The following is a description of a gene set: Genes having at least one occurrence of the motif AGATADMAGGGA in the regions spanning 4 kb centered on their transcription starting sites. This matches the GATA4 transcription factor binding site V$GATA4_Q3 (v7.4 TRANSFAC). studied in species Homo sapiens Human Gene Set: GATA4_Q3, and this is the list of marker genes: SMAD6, LHX6, POU6F2, TSHZ2, EBF1, SOX2, ARF6, WFIKKN2 (WAP, follistatin/kazal, immunoglobulin, kunitz and netrin domain containing 2), GTF2A1, LYVE1, FNBP1L (NCBI Gene Id 54874), LHX4, CNTF, HTR2B (NCBI Gene Id 3357), CLDND2, NEXN, PPP1R3D, ACTN1, SP6, HOXB2, RASAL2, ESRRG, LMO3, TEX9, SMC1B, FAM53B, CREB3, MYB, MAP3K20, DLG2, TMEM164, PA2G4, SOSTDC1, ATP12A, HOXA3, ASB3, TCF7L2, ZIC4, LHFPL1, GPC6, PARP8, RFX5, PTCD3, LMO2, YWHAG, JARID2, EGFL7, TMEM71 (transmembrane protein 71), CAPN1, HOXC4, HSPB2, HOXD3, TFAP2D, NDP, ELAVL2, SNX20, PTMS, ANKRD28, DGKA, GPHA2, SLCO5A1, ALDH4A1, LNPEP, UBE2D1 (ubiquitin conjugating enzyme E2 D1), CBL, MYRF, CXCL5, MEIS1, CELF4, PIM2, CHN2, CXXC5, CNR1, LRRTM3, ZNF654, ALK, GPR21, SREK1, SEPTIN9, CCDC138, SH2D3C, DSG4, SF1, SCUBE1, SLC8A3, MID2, IKZF2, ATP2B4, PYM1, RAPGEFL1, PCDHGA5, RHOG, PHF21A, TMEM178A, SLC16A6, GPX1, HMGN5, PPP2R5C, WNT16, CARF, CPEB4, SOX5, PDE4D, BCL6, TNRC6A, RIBC2, COA3, POLR1A, IL4, SLTM, RTKN2, IL10, TRERF1, TLN1, SCN3A, PCF11, MAZ, ZNF462, ADGRB2, FOXP2, ERLEC1, CSN2, C12orf50, CTNND1, LIF, ADGRL1, PLSCR3, SLC35A1, SLC25A28, LENG9, NEUROG2 (NCBI Gene Id 63973), FST, ZNF366, PIP5K1B, SEMA3A, MIDEAS, LIX1, ZBTB18, SRSF8, LIFR, C6orf62, CPLANE1, BICDL1, LIX1L, DMD, BMP4, BNC2, HOXC11, NR2F2, TMOD3, NOS1, NEDD4L, HOXA7, OTX2, KLHDC8B, KCNQ4, ZIC1, AMD1, PI15, MYOT, FGF23, OLIG3, EGR3, VEGFD, LRRTM4, CXCR5, TMEM154, AMOT, VGF, DLL4, ETFB, TOB1, ETS1, TPT1, FCRLA, LBX1, PSEN1, RBM14, JADE2, HHIP, CCM2L, PRKAG1, VPS11, FGF16 (fibroblast growth factor 16), MBNL1, ZEB2, NRP1, LINC01101, ECT2, TNFRSF19, TFDP2, ARPP21, NPPB, MFSD14B, TOMM20, MARCKSL1, SSBP3, BTG2, ERF, NFKB2, B4GALNT1, CRYAB, LAMTOR1, DNAH17, COL15A1, HIRA, CHCHD7, CHRM1, EVX1, POU4F2, PNMA1, PLAG1, MRPS18B, PPARGC1A, RUNX1T1, MIR9-1HG, E2F3, SMARCE1, PURA, KRIT1, CXCL6, ARHGEF2, AKAP6 (NCBI Gene Id 9472), GPR173, CNTD1, FAM217B, FOXD3, HINT1, DDX17, TMEM88, RGS1, PLAGL2, STC1, SLC26A9, FCGR1A, PLXNA2, TRPC5, LSM12, OVOL1 (NCBI Gene Id 5017), NNAT, ID2 (NCBI Gene Id 3398, inhibitor of DNA binding 2), AUTS2, PCYT1B, POFUT1 (protein O-fucosyltransferase 1), BEND4, TMEM100, ATP2B3, GRM1, ZNF521, STAG2, NKX2-1, FSBP, MEIS2